The following is a description of a gene set: Any process in which a receptor is transported to, and/or maintained at the synapse, the junction between a nerve fiber of one neuron and another neuron or muscle fiber or glial cell. Mouse Gene Set: GOBP_RECEPTOR_LOCALIZATION_TO_SYNAPSE species: Mus musculus, and this is the list of marker genes: Dag1, Clstn1, Rab4a, Nbea, Slc12a5, Tnik, Iqsec2, Cacng7, Cacng5, Vwc2, Cnih2, Kif5c, Cnih3 (cornichon family AMPA receptor auxiliary protein 3), Snap47, Stx7, Vps35, Zdhhc3, Nptx1, Gripap1, Nptx2, Anks1b, Cplx1, Adam10, Tyrobp, Mylk, C1ql3, Agrn, Adam22, Lgi1, Neto2, Gsk3b, Rapsn, Cacng2, Hras, Dlg2, Rab8a, C1ql2, Cacna2d2, Magi2, Ghsr, Dlg4 (NCBI Gene Id 13385), Traf6, Gabarap, Mkln1, Rap1a, Lrrc7, Gphn, Cacng3, Zdhhc2, Gpsm2, Kalrn, Grip1, Itgb3, Kif5b, Rapgef4, Erbb4, Nrxn1, Kif3a, Nptxr, Shisa6, Cacng4, Dbn1, Tmem108, Git1, Neto1, Map2k1, Musk, Reln, Camk2a, Sacm1l, Gpc4, Dlg1, Kifc2, Nlgn1, Arhgap44, Prkcz, Dlg3, Vamp2, Mapk10, Lhfpl4, Kif5a, Erbb2, Rdx, Snap23, Nrxn3, Stx3, Scrib, Stx4a (NCBI Gene Id 20909), Cacng8, Olfm2, Stx1b, Kif3b, Vps26b, Gpc6, Grip2, Kif2c, Kifap3 (kinesin-associated protein 3), Cep112, Dok7, Itgb1, Ogt, Epb41l1, Nsg1, Kif17, Rab11a, Nptn